Given this list of marker genes Foxp3 (forkhead box P3), Il33, Prkcz, Icosl, Gata3, Fcer1g, Cd1d2, Prg2, Irf4, Slc7a5, Cd40lg, Il20rb, Cd28, Nlrp3, Il1rap (NCBI Gene Id 319228), Havcr2, Cebpb, Epx, Syk, Rara, Cd1d1 (NCBI Gene Id 99710), Sash3, Zp3, Cd3e, H2-T23, Prkcq, Tnfsf4, here is a description of the gene set: Any process that activates or increases the frequency, rate, or extent of interleukin-4 production. studied in species Mus musculus Mouse Gene Set: GOBP_POSITIVE_REGULATION_OF_INTERLEUKIN_4_PRODUCTION